The following is a description of a gene set: MDA5-IRF7/3 signaling pathway. Pathway ID: N01308. Pathway type: Reference. Pathway class: nt06519 RLR signaling. Pathway Definition from KEGG: RNA -> MDA5 -> MAVS -> TRAF3 -> (TANK+NAP1+SINTBAD) -> (TBK1+IKBKE) -> (IRF7,IRF3) => (IFNA,IFNB1) species: Homo sapiens Human Gene Set: KEGG_MEDICUS_REFERENCE_MDA5_IRF7_3_SIGNALING_PATHWAY, and this is the list of marker genes: IFNA10, IFNA21, IFNA8, IFNA7, IKBKE, IFNA5, TANK, IFNA6, IFNA13, IRF3, IFNA16, IFNB1, IFNA1, TRAF3, MAVS, IRF7, AZI2, IFIH1, IFNA17, TBK1, IFNA4, IFNA14, TBKBP1, IFNA2